The following is a description of a gene set: Mouse Gene Set: GOBP_CARDIAC_MUSCLE_CELL_FATE_COMMITMENT studied in species Mus musculus The commitment of cells to specific cardiac muscle cell fates and their capacity to differentiate into cardiac muscle cells. Cardiac muscle cells are striated muscle cells that are responsible for heart contraction., and this is the list of marker genes: Nkx2-5, Tbx18, Rbpj, Wnt3a, Acvr1, Tbx5, Tbx3, Wt1, AW551984